Given this list of marker genes SCARA3, RTN2, MGAT4B, PLK1, PIP4K2A (phosphatidylinositol-5-phosphate 4-kinase type 2 alpha), DEXI, ARPC1A, TGFA, APPL2, PRSS23, BCAT2, ERC2, FECH, SVIL, CCND3, EPB41L4B, SLC7A11, PADI3, ALCAM, SCD, NHERF1, SMAGP, GPSM2, HNRNPA0, CAP2, EXT2, ESYT1, CTDSPL, SEMA6B, MYO5C (NCBI Gene Id 55930), MYH10, E2F1, UBXN8, LRP4, VAMP1, LASP1, ASB1, MGST3, MXRA7, PLXNA1, ANXA6, COTL1 (coactosin like F-actin binding protein 1), POU6F2, SLC25A10, TBL1X, H2AZ1, PALLD, CLEC16A, EEIG1, DDX11, CAPN2, CCNB2, CNPPD1, PIP (prolactin induced protein), CREB3L2, PCOLCE2, PHKB, HACD1, AHCYL1, FAM168B, GNB1, B3GNT2, GSTM3, PRORP, PLCXD1 (NCBI Gene Id 55344), EMC9, JAG2, CERK, PRSS3, PDGFD (NCBI Gene Id 80310), HJURP, SLC25A11, KIF1C, SPA17, DLX4, GSTM4, UCHL3, ABHD10 (abhydrolase domain containing 10, depalmitoylase), MYBL2, NF2, CYB5R1, UNC13B, GPC1, FAM114A1, MLF2, CHST15, PAPOLG, MALL, USP22, EBP, GCG, IFT140, SYT2, VSNL1, GSTA4, FBXW2, SPANXC, MEGF9, VCL, PDGFC, MAPK1IP1L, CHPT1, LRRC47 (leucine rich repeat containing 47), RAB40B, USP13, FBN2, GM2A, ANKRD28, PRKCH, PLCB2, KLHDC10, CD1D, SLC3A1, RHOD, AMZ2, GAS2L1, ATP6V1H, DPY19L1, SOX9, TRIM14, TPCN1, GLDC, MPC2 (NCBI Gene Id 25874), C1orf21, SIPA1L3, UNC119B, CGREF1 (cell growth regulator with EF-hand domain 1), PLOD3, PLAAT1, FZD2, ATP6V0C, SH2D3C, TNFSF9, IGSF3, CCDC103, HPCAL1, ARPP19, SMTN, TUBA1A, MGLL, HDHD5, ABCA12, NT5DC2, ADGRL3, PDLIM2, OR10J1, CORO2B, TMLHE, AQP3, HSPA12A, FAM171A1, SERINC5, SIRPG, CST6, FLII, DLG1, MAGEA4, POMGNT1, GYG2, PLCE1, CCNB1, ITPKB, KIFBP, CUL4B, SDCBP, AHNAK2, BRME1, PDXDC1, TMCO3, UPK1B, TAPT1, SAC3D1, MTSS2, BARD1, PHKA2, AGO2, UCP2, SIT1, CAVIN1, CSK, MMP24, EPB41L1, MARF1, TAX1BP3, KIAA0232, INPP5A, APOOL, LDHC, PPP1R16B, MYL7, KANK2, TIMM10, EFHC1, OLFML2A, TMF1, PRKAR2A, AP1M2, EML1, BAIAP2, CBX5, here is a description of the gene set: Human Gene Set: GSE42021_CD24HI_VS_CD24LOW_TCONV_THYMUS_UP We investigated at which stage of maturation commitment to a stable Foxp3-expressing phenotype takes place. We assessed stability of Foxp3 expression in thymic Foxp3+ Treg subsets of different maturity, defined by CD24 expression. Next we compared gene expression profiles of Foxp3+ Treg subsets (+) of different maturity (24lo, 24int, 24hi) and could identify a set of genes that were specifically up or downregulated in Foxp3+ Tregs, but not in Foxp3- conventional T cells, in a maturation-dependent manner. studied in species Homo sapiens from publication Toker A, Engelbert D, Garg G, Polansky JK, Floess S, Miyao T, Baron U, Düber S, Geffers R, Giehr P, Schallenberg S, Kretschmer K, Olek S, Walter J, Weiss S, Hori S, Hamann A, Huehn J (PMID 23420886) Genes up-regulated in thymic T conv: CD24 high versus CD24 low.